Given this list of marker genes WNT5A, JAM2, CCR2, CCL4, PTK2B, CCL5, STK39, TNFSF14, MADCAM1, S100A7, CCL21, ITGA4, ASCL2, ADAM10, CXCL12, SPN (NCBI Gene Id 6693), AIF1, CXCL10, OXSR1, TNFRSF14, CORO1A, CCL7, CCL20, ITGB3, MED23, PYCARD, NEDD9, APP, ABL1, P4HB, XCL1, TMEM102, ADAM8, LGALS9, ABL2, DOCK8 (NCBI Gene Id 81704), CCL3, WNK1, RHOA, SELENOK, FADD, ADAM17, CD99L2, CXCL13, here is a description of the gene set: Human Gene Set: GOBP_POSITIVE_REGULATION_OF_LYMPHOCYTE_MIGRATION Any process that activates or increases the frequency, rate or extent of lymphocyte migration. species: Homo sapiens